Given this list of marker genes Pld6, Huwe1, Miga1, Mtch2, Mfn2, Vat1, Stoml2, Bax (NCBI Gene Id 12028), Thg1l, Afg3l2, Dnm1l, Bcl2a1c, Yme1l1, Mfn1, Fis1, Trabd, Adck1, Mcl1, Bcl2a1b (B cell leukemia/lymphoma 2 related protein A1b), Nme3, Tfrc, Mul1, Bnip3, Bcl2a1a, Rcc1l, Opa1, Usp30, Prkn, Fundc1, Zdhhc6, Bcl2a1d, Gdap1, Miga2, Afg3l1, Mief1, Oma1, Chchd3, Bak1, Mff, Parl, here is a description of the gene set: Mouse Gene Set: GOBP_MITOCHONDRIAL_FUSION Merging of two or more mitochondria within a cell to form a single compartment. studied in species Mus musculus